The following is a description of a gene set: Response of EIF2AK4 (GCN2) to amino acid deficiency studied in species Homo sapiens Human Gene Set: REACTOME_RESPONSE_OF_EIF2AK4_GCN2_TO_AMINO_ACID_DEFICIENCY, and this is the list of marker genes: RPS5, RPS15, RPL29, RPL4, RPL35A, RPL11, RPL37A, RPL10A, RPL5, RPL38, RPL7, RPS26, RPL12, ASNS, TRIB3, CEBPB, RPS7, EIF2S2, RPS27A, GCN1, RPS3A, EIF2AK4, RPL14, RPS20, RPL23, RPL13A, RPS24, RPL36A, RPL18, RPS18, RPS13 (NCBI Gene Id 6207), RPL10, RPL36AL, RPS29, RPL3, RPS10, RPL26, RPL31 (NCBI Gene Id 6160), RPS27, RPS3, RPL15, RPS2, RPL10L (NCBI Gene Id 140801), RPL23A, ATF4, RPL19, RPS14, RPL41, RPS28, UBA52, RPL18A, RPS23, RPLP0, RPL8, RPS27L, RPL35 (NCBI Gene Id 92393), RPS6, EIF2S3, RPL7A, RPS9, RPL21, RPL32, FAU, RPS4Y1, RPL9, RPS11, RPS8, RPL27, RPL39, RPL6, RPLP2, RPL39L, RPS17, RPS16, RPL13, RPL26L1, RPLP1, RPL22, RPL27A, ATF3, IMPACT, ATF2, RPL28, RPL34, RPS4X, RPL3L, RPS12, RPL17, RPS4Y2, RPL22L1, CEBPG, RPL37, RPL36, EIF2S1, RPS19, RPSA (ribosomal protein SA), RPS25, DDIT3, RPS21, RPS15A, RPL24, RPL30